The following is a description of a gene set: Genes predicted to be targets of miRBase v22 microRNA mmu_miR_10a_5p, mmu_miR_10b_5p in miRDB v6.0 with MirTarget v4 prediction scores > 80 (high confidence targets). from publication Chen Y, Wang X (PMID 31504780) studied in species Mus musculus Mouse Gene Set: MIR_10A_5P_MIR_10B_5P, and this is the list of marker genes: Hoxa3, Cadm1, Patl1, Pfkfb2, Klhl29, Purg, Tnrc6b, Camk2b, Mycs, Rtn4r, Fam243, Rgs8, Sdc1, Six4, Prtg, Cdc42bpa, Crk, Clcc1, E2f7 (E2F transcription factor 7), Ankrd6, Tfap2c, Id4, Mapkbp1, Tmem132b, Kcnq2, Nsd3, Actg1, Gpr3, Bicd2, Rb1cc1, Dlgap2, Fign, Rora, Vwc2l, Cadm2, Trim2, Grin3a, Nr5a2, Lgalsl, Tbx5, Sec22c, Spef2, Cnot6, Bcl2l11, St3gal4, Dhfr, Atf2, Ggt5, C4a, Shank3, Abcb7, Hcn1 (NCBI Gene Id 319874), Hoxd10, Bbx, Epha8, Zfp64, Tox4, Gata6, Creb1, C4b, Zfp367, Gabrb2, Ptpn4, Kcna6, Tmod1, Mdga2, Wnt9b, Spag9, Lhfpl4 (NCBI Gene Id 68914), Hoxb3, Dock11, Rhpn2 (NCBI Gene Id 97401), Bdnf, Slc35e1 (NCBI Gene Id 270066), Ivns1abp, Usp46, Usp45, Ebf2, Pcdh10, Abcg1 (ATP binding cassette subfamily G member 1), Pgm3, Suv39h2, Son, Slc35g1, Nr4a3, Klf11, Galnt1, Nr6a1, Smap1